The following is a description of a gene set: from publication Baker DA, Barth J, Chang R, Obeid LM, Gilkeson GS (PMID 20644167) Human Gene Set: GSE20152_HTNFA_OVERXPRESS_ANKLE_VS_CTRL_SPHK1_KO_ANKLE_UP studied in species Homo sapiens The study analyzes analyzes gene expression changes in the ankle joint in mouse TNFa overexpression models with or without sphingosine kinase 1 activity. SphK1 is a sphingolipid enzyme that converts sphingosine to bioactive sphingosine-1-phosphate (S1P). Recent data suggest a potential relationship between SphK1 and TNFα and have implicated SphK1/S1P in the development and progression of inflammation. Here we further study the relationship of TNFα and SphK1 using an in vivo model. Transgenic hTNFα mice, which develop a spontaneous arthritis (limited to paws) at 20 weeks, were crossed with SphK1 activity null mice (SphK1-/-) to study the development of inflammatory arthritis in the functional absence of SphK1. Results show that hTNF/SphK1-/- have significantly less severity and progression of arthritis and bone erosions as measured through micro-CT images. Additionally, less COX-2 protein, mTNFα transcript levels and fewer Th 17 cells were detected in the joints of hTNF/SphK1-/- compared to hTNF/SphK1+/+ mice. Microarray analysis of the ankle joint showed that hTNF/SphK1-/- mice have increased transcript levels of IL-6 and SOCS3 compared to hTNF/SphK1+/+ mice. Finally, fewer mature osteoclasts were detected in the ankle joints of hTNF/SphK1-/- mice compared to hTNF/SphK1+/+ mice. These data show that SphK1 plays a role in hTNFα induced inflammatory arthritis, potentially through a novel pathway involving IL-6 and SOCS3. Genes up-regulated in ankle joints from SPHK1 knockout: TNF over-expression versus control., and this is the list of marker genes: MAMLD1, GP9, LYPLA2P1 (LYPLA2 pseudogene 1), BTG3, TMEM39A, SLC15A1, MCC, TSPOAP1, TGFB1, KCNQ3, METTL22, PLA2G4C, PKNOX2, SNAI1, PSMD12, HGS, MTRF1L, FNDC8, MAGEA5P, NFKBIB, CSF1R, FAM3C, MTF1, BIN3, PVR, SFPQ, CNIH4, FARP1, ZNF140, RPS27, DST, POU2AF1, PXN (NCBI Gene Id 80229), SNAP91, SLIT3, APOBR, WHRN, ACVR1B (NCBI Gene Id 93351), GPRC5A, TSC22D2, RGS20, NRIP3, MSC, MED17, ITCH, CST8, PTPN1, TOPORS, FXYD1, GATA2, BARX1, LRRFIP2, PPP1R11, MAPKAPK2, ZNF365, XIAP, ZNF611, UNC5C (NCBI Gene Id 8633), TTC4, CDV3, PIGA, PPARG, LXN, TRBC1, OR1F2P (NCBI Gene Id 26745), TAF7, ARF6, USP7, ANK1, MICALL2, RND2, NRG1, FCGR2C, FASTKD2, RAB3GAP1, FER1L4 (NCBI Gene Id 80717), KCTD15, EIF2B2, GFPT1, CAPN5, CLMN, SCN11A, BZW1, TRIP11, KCNN4, IFNA21, PFKFB3, HSPA6, EDRF1, PGBD5, STX1A, TMUB2, RAB22A, SLC25A32, PLPPR2, AZI2, MAGEA4, RABGGTB, CHRNB2, MPPED1, PDE9A, KLC1, AGPAT5, ELP5, CDKL2, FBXO28, SVEP1, GAK, KCND1, TAF4, ZSCAN18, AMBP, FGF7, ATP2A2, SDC3 (syndecan 3), PAFAH1B1 (platelet activating factor acetylhydrolase 1b regulatory subunit 1), DCP1A, EGLN3, ARF4, DAPK2, LAT2, SNAPC2, LMCD1 (NCBI Gene Id 29995), NDRG4, PRAMEF11, ZNF432, SLC12A3, COPZ2, CBX4, TNK2, HS2ST1, ACTN2, KLRD1, RPL23AP7, MAP2K3, TVP23B, MAGEB3, KDM5C, VAMP2, PPFIBP1, KHDC1L, MAGEA12, PRDM2, LPIN1, ARSF, COPB1, GRAMD2B, RECK, CRABP2, OR1E1, TNFSF14, PPIF, LAMA5, ASCC1, UFM1, CSF2, RGS12, S100A6, ARIH1, AKAP8, UGCG, PPP1R2C, MYBPC3, AMD1 (adenosylmethionine decarboxylase 1), PHLPP2, AMMECR1, HMGA1, CLIC1, GLS, B4GALT1, TRDMT1, SOX4, HBB, MARCHF7, MFSD10, GJB5, GNL2, KLF3, CAMK2A, RUSC2, CTRC, OSMR, DAPP1, SNED1, NFATC4, PICK1, GP5, KCND3, RTN1, MON2, R3HDM4, ARHGAP33, ETV7 (NCBI Gene Id 51740), SH3GL3, CHPF2, SCNN1A